The following is a description of a gene set: Human Gene Set: SA_MMP_CYTOKINE_CONNECTION studied in species Homo sapiens Cytokines can induce activation of matrix metalloproteinases, which degrade extracellular matrix., and this is the list of marker genes: SPN, TNFRSF1B, TGFB2, TGFB1 (transforming growth factor beta 1), SELL, TNF, CD44, ACE, IL1B, CSF1, FCGR3A, IL6R, TNFSF8 (NCBI Gene Id 944), TNFRSF8, TNFRSF1A